The following is a description of a gene set: Systems biology is an approach to comprehensively study complex interactions within a biological system. Most published systems vaccinology studies have utilized whole blood or peripheral blood mononuclear cells (PBMC) to monitor the immune response after vaccination. Because human blood is comprised of multiple hematopoietic cell types, the potential for masking responses of under-represented cell populations is increased when analyzing whole blood or PBMC. To investigate the contribution of individual cell types to the immune response after vaccination, we established a rapid and efficient method to purify human T and B cells, natural killer (NK) cells, myeloid dendritic cells (mDC), monocytes, and neutrophils from fresh venous blood. Purified cells were fractionated and processed in a single day. RNA-Seq and quantitative shotgun proteomics were performed to determine expression profiles for each cell type prior to and after inactivated seasonal influenza vaccination. Our results show that transcriptomic and proteomic profiles generated from purified immune cells differ significantly from PBMC. Differential expression analysis for each immune cell type also shows unique transcriptomic and proteomic expression profiles as well as changing biological networks at early time points after vaccination. This cell type-specific information provides a more comprehensive approach to monitor vaccine responses. from publication Hoek KL, Samir P, Howard LM, Niu X, Prasad N, Galassie A, Liu Q, Allos TM, Floyd KA, Guo Y, Shyr Y, Levy SE, Joyce S, Edwards KM, Link AJ (PMID 25706537) Genes down-regulated in natural killer cell 3d vs 0d in adults after exposure to 2011-2012 trivalent inactivated vaccine (A/California/7/09 (H1N1), A/Perth /16/2009 (H3N2), B/Brisbane/60/2008), time point 3D. Comment: Down-regulated DE RNA transcripts (down >= 1.5x) shared between both TIV-vaccinated donors Human Gene Set: HOEK_NK_CELL_2011_2012_TIV_3D_VS_0DY_ADULT_3D_DN species: Homo sapiens, and this is the list of marker genes: CD101, FAM20C, PELATON, TYMP, VIPR1, IRS2, JUN (Jun proto-oncogene, AP-1 transcription factor subunit), ADGRE2, NFE2, GNA15, NLRP12 (NLR family pyrin domain containing 12), MIR3198-2, LTBR, CSF2RB, CSTA, PYGL, CD14, ARHGEF11, CSF2RA, GCA, RASGRP4, VAV2, LMO2, DMXL2, P2RY13, NPB, NCF4, MYCL, PTAFR, SORT1, MIR3648-1, MEFV, IFI30, RBP7, SLC43A2, RABGEF1 (RAB guanine nucleotide exchange factor 1), SAMD11, CLEC7A, LYL1, LILRB4, LRRC25, LYZ, SLCO5A1 (NCBI Gene Id 81796), CES1, CIITA, PLAUR, JAML, CYP2S1, CIMAP1B, DLG2, RAB32, IL13RA1, SLC11A1, CTSH, CD4, RNU1-1, SOCS1, TMEM88 (NCBI Gene Id 92162), C19orf38, ZNF703, LILRA1, TMEM150B, SECTM1, AVPI1, ANKRD30BL, CD86, SNORD5, CEBPB, LRRC24, ALDH2, IFNGR2, HLA-DQB1, CBFA2T3, MIR571, SNORA8, VCAN, IGSF6, MISFA, ADAMTSL4, KCNQ1, IDI2, LRP1, SNORA27, SNORA73B, LILRA3, TUBB2A, CARS1-AS1, ANPEP, PLA2G7, CYBB, PLXNB2, PID1, TLR4, TNFSF13B, LNX1, SNORC, ELOA-AS1, TLR2, ALOX5, P2RX1, MYOF, RNASE2, NCF2, CTRL, YBX3, SPI1, TMED7-TICAM2, NID1, CD300LF, IL6R, CFAP206, TNFAIP2, CEACAM4, KCNMB1, DOK3, DNPH1, KCNC3 (NCBI Gene Id 57363), GRK3, ARMH1, ASGR2, RAB34, SERPINA1, MS4A6A, SNORD102, TGFBI, CLEC4A, C5AR1, LILRA2, LY86, TFEC, NIBAN2, ASB13, RETN, CXCL16, CDKN1A, UNC45B, ZMYM4-AS1 (NCBI Gene Id 100861513), OSM, SIRPB2, SIRPB1, FOSB, GABBR1, CD300E, ATP4A, RTN1, LRRK1, DUSP1, FCN1, HFM1, SCARF1, MARCKS, S100A9, PLA2G4B, CSF3R, VCAN-AS1, SYNJ2BP-COX16 (SYNJ2BP-COX16 readthrough), MARVELD1, GASK1B, LILRA6, CHST15 (NCBI Gene Id 9916), LHFPL5, TLR5, KCTD12, HCK, PDE3A, TRIB1, HLA-DRA, HLA-DQA1, SPINT2, FCER1A, FGD2, SULF2, ARHGEF40, LILRB2, S100A8, MS4A7, MPEG1, NR4A2, NLRP3, NT5C1B-RDH14, CD1D, SNORD4A, CREB5, HLA-DRB1, PRAM1, JUP, SIGLEC14, CD163, ATF7-NPFF, FPR1, NFAM1, VENTX, PDK4, OSCAR, SLC37A2, DPYD-AS1, S100A12, CFD, HK3, CD33, CFP, KCNE3, ZFP36, CPVL, WAKMAR2, NR4A1, SNORA40, NCF1, MAFB, TNFSF12-TNFSF13, SNORA25, JUNB, CST3, MTMR11, LILRA5, BTK, PEDS1-UBE2V1, SLC15A3, FRS3, CD5, MIR2110, HRH2, ZNF385A, SIRPA, STAB1, BST1, CD36, TAMALIN, SLC2A6, TLR8 (NCBI Gene Id 92553), GPSM1, LRRK2, AATBC, OAF, PFKFB4, TBC1D9, EGR1, PADI2, APOBEC3A, AIF1, KLF4, GCC2-AS1, CLEC10A, SEMA4A, SETD7, SLC7A7, ANKRD9, PER1, LILRB3, MNDA, PLBD1, CHADL, HLA-DOA, TIMP2, HLA-DRB5, SPINT1, F13A1, CSF1R